The following is a description of a gene set: species: Homo sapiens Human Gene Set: GOMF_HISTONE_H4_METHYLTRANSFERASE_ACTIVITY Catalysis of the reaction: Catalysis of the reaction: S-adenosyl-L-methionine + a histone H4 = S-adenosyl-L-homocysteine + a methylated histone H4. Histone methylation generally occurs on either an arginine or a lysine residue., and this is the list of marker genes: NSD2, PRMT8, PRMT5, KMT5A, SETD4, NSD1, PRMT3, PRDM9, SMYD5, PRMT6, N6AMT1, TTLL12, KMT5B, PRDM6, KMT5C, PRMT1, SMYD3, PRMT7